The following is a description of a gene set: Human Gene Set: GOBP_POSITIVE_REGULATION_OF_LYMPHOCYTE_CHEMOTAXIS studied in species Homo sapiens Any process that activates or increases the frequency, rate or extent of lymphocyte chemotaxis., and this is the list of marker genes: ADAM17, PTK2B, WNT5A, OXSR1, CCL7, S100A7, STK39, CCL3, CCL5, CCL21, XCL1, WNK1, NEDD9, CCR2, TNFSF14, CCL4, TMEM102, CXCL13, ADAM10